Given this list of marker genes Ldhb, Adm, Eif4e3, Nr4a2, Steap4, Hoxa13, Col2a1, Eda, Postn, Jam2, Kif21a, Tbx15, Gata4, Il20ra, Pax3, Dpep1, Dll1, Plek, Slit2, Shox2, Nt5dc2 (NCBI Gene Id 70021), C2, Tmem119, Cnnm2 (NCBI Gene Id 94219), Rabgap1l, Kazald1, Tmem140, Scel, Kcnj15, Thbd, Hoxc10, Pde9a, Hoxc13, Hlf, Ptges, Sash1, Mst1r, Ptprm, Dkk3, Wfdc21, Cxcl2, Mmp13, S1pr3, Pcdhb16, Fabp4, Ppm1l, Dmbx1, Pthlh, Ccdc80, Htr2a, Grip1 (glutamate receptor interacting protein 1), Cyba, Shc4, Fam20a, Efhd1, Stxbp6, Arid5b, Arhgef6, Rgs16, Smoc1, Nfatc4, Vmn1r226, Adam19, Dab2, Alx1 (NCBI Gene Id 216285), Cnksr3, Lpxn, Islr, Il6, Stox2, Abhd3, Galnt12, Scp2, Fes, S1pr1, Svep1, Eva1a, Nadk2, Itih2, Cyp2s1, Fam13a, Hoxa10, Clmp, Zic2, Enpep, Pkp3, G0s2, Cd14, Hs6st2, Etv1, Sprr1a, Glt8d2, Chi3l1, Aspa, Lrig3, Rnf144b, H2-T24, Col6a1 (collagen, type VI, alpha 1), Frzb, Cpq, Ebf1, Ttc9, Twist2, Rnf130, Rnf144a, Kcnj2, Hoxb5, Isl2, Calhm5, Pax9, Ugp2, Emc2, Tbc1d8, Pitx2, Minar1, Mmp14, Gng8, Vegfc, Reno1, Tmem51, Cpz, Slc16a7, Mmp2 (matrix metallopeptidase 2), Zcwpw1 (NCBI Gene Id 381678), Cables1, Emilin1, Gstt3, Kctd12b, Gata6, Napepld, Slc10a6, Parp14, Ccdc68, Scarf2, Plac8, Hcar2, Atp2b1, Rspo2, Ebf3, Dapp1, Arhgap26, Peli2, Amigo2, Asb15, Gpm6b (NCBI Gene Id 14758), Zfp503, Tgm1, Fbxl7, Notum, Mme, Tgfbr3, Fndc3a, Abca9 (NCBI Gene Id 217262), Naalad2, Cacna1g, Fbn2, Hccs, Fut11, Gal3st1, Dlx2, Pax1, Gstt2, Kcna4, Fgf10, Dpyd, Isoc2b, Negr1, Sfrp1 (NCBI Gene Id 72362), Gpx7, Smpdl3b (sphingomyelin phosphodiesterase, acid-like 3B), Arhgap18, Ptpn22, Abi3bp, Foxs1, Krt13, Grb10, Dhrs3, Slc8a3, Selenop, Hoxc5, F5, Aspn, Plek2, Wnk4, Cdhr1, Vax2, Larp6, Agt, Mgp, Omd, Map3k5, Col10a1, Foxd1, Sfrp2, Il1rn, Rab3il1, Rps6ka6, Tmem35a, Cish, Hoxb6, Slc7a2, Mylip, Def6, Osr2, Clip4, Sh3rf3, Lgals3bp, Maf, Fam3c, Rsrc1, Sox5, Mapk13, Pax6 (paired box 6), Kcnc2, Ptgfr, Angpt1, Enpp1, Sh3rf2, Hnf1b, Sned1, Rtn4rl1, Adora2b, Fabp7, Cdo1, Hdac9, Rubcnl, Pnma2, Adh1, Frmd5, Lhfpl1, Baiap2l1, Emb, Apobec3, Ces2e, B3galt4, Stat5a (NCBI Gene Id 20850), C4bp, Esr1, Dgka, Pdk4, Meg3, Thbs2, Spon2, Igf2bp3, Pcdhb15, Ano4, Gdf6, Igfbp6, Nfia, Ndnf, Rsph9 (NCBI Gene Id 75564), Tgfbi, Hoxc6, Mrc2, Cyp2f2, Smoc2, Mafb, B4galnt4, Cacna1a, Lama1, Dusp2 (NCBI Gene Id 13537), Hoxc9, Aldh2, Enpp3, Tox, Foxc2, Cdkn2c, Hsd11b1, Serpinb10, Sh3tc1, Frat2, Rida, Cys1, Pcbd1, Rassf9, Egr3, Gata3, Nkx6-1 (NK6 homeobox 1), Col14a1, Arhgdib, Avpr1a, Pla2r1, Hoxc8 (homeobox C8), BC030500, Hoxb3, Slc27a3 (NCBI Gene Id 26568), Il1rl1, Col6a2, Hoga1, Ar, Slco2a1, Esx1 (extraembryonic, spermatogenesis, homeobox 1), H6pd, Bnc1, Foxc1, Slit3, Gda, Trem2, here is a description of the gene set: from publication Wang P, Lin C, Smith ER, Guo H, Sanderson BW, Wu M, Gogol M, Alexander T, Seidel C, Wiedemann LM, Ge K, Krumlauf R, Shilatifard A (PMID 19703992) species: Mus musculus A common landmark of activated genes is the presence of trimethylation on lysine 4 of histone H3 (H3K4) at promoter regions. Set1/COMPASS was the founding member and is the only H3K4 methylase in Saccharomyces cerevisiae; however, in mammals, at least six H3K4 methylases, Set1A and Set1B and MLL1 to MLL4, are found in COMPASS-like complexes capable of methylating H3K4. To gain further insight into the different roles and functional targets for the H3K4 methylases, we have undertaken a genome-wide analysis of H3K4 methylation patterns in wild-type Mll1(+/+) and Mll1(-)(/)(-) mouse embryonic fibroblasts (MEFs). We found that Mll1 is required for the H3K4 trimethylation of less than 5% of promoters carrying this modification. Many of these genes, which include developmental regulators such as Hox genes, show decreased levels of RNA polymerase II recruitment and expression concomitant with the loss of H3K4 methylation. Although Mll1 is only required for the methylation of a subset of Hox genes, menin, a component of the Mll1 and Mll2 complexes, is required for the overwhelming majority of H3K4 methylation at Hox loci. However, the loss of MLL3/MLL4 and/or the Set1 complexes has little to no effect on the H3K4 methylation of Hox loci or their expression levels in these MEFs. Together these data provide insight into the redundancy and specialization of COMPASS-like complexes in mammals and provide evidence for a possible role for Mll1-mediated H3K4 methylation in the regulation of transcriptional initiation. Mouse Gene Set: WANG_MLL_TARGETS Genes requiring MLL for H3K4me3 and expression in MEF cells (embryonic fibroblast).